The following is a description of a gene set: Human Gene Set: GSE9988_LPS_VS_CTRL_TREATED_MONOCYTE_DN studied in species Homo sapiens Genes down-regulated in comparison of monocytes treated with 5000 ng/ml LPS (TLR4 agonist) versus monocytes treated with control IgG. from publication Dower K, Ellis DK, Saraf K, Jelinsky SA, Lin LL (PMID 18292579) TREM-1 is an orphan immunoreceptor expressed on monocytes, macrophages, and neutrophils. TREM-1 associates with and signals via the adapter protein DAP12/TYROBP, which contains an immunoreceptor tyrosine-based activation motif (ITAM). TREM-1 activation by receptor cross-linking is pro-inflammatory, and can amplify cellular responses to Toll-like receptor (TLR) ligands such as bacterial lipopolysaccharide (LPS). To investigate the cellular consequences of TREM-1 activation, we have characterized global gene expression changes in human monocytes in response to TREM-1 cross-linking in comparison to and combined with LPS. Both TREM-1 activation and LPS up-regulate chemokines, cytokines, matrix metalloproteases, and PTGS/COX2, consistent with a core inflammatory response. However, other immunomodulatory factors are selectively induced, including SPP1 and CSF1 (i.e., M-CSF) by TREM-1 activation and IL-23 and CSF3 (i.e., G-CSF) by LPS. Additionally, cross-talk between TREM-1 activation and LPS occurs on multiple levels. While synergy in GM-CSF protein production is reflected in commensurate mRNA abundance, comparable synergy in IL-1b protein production is not. TREM-1 activation also attenuates the induction of some LPS target genes, including those that encode IL-12 cytokine family subunits. Whereas positive TREM-1 outputs are abolished by the PI3K inhibitor wortmannin, this attenuation is largely PI3K-independent. These experiments provide a detailed analysis of the cellular consequences of TREM-1 activation, and highlight some of the complexity in signal integration between ITAM- and TLR-mediated signaling., and this is the list of marker genes: APOBR, BRD1, KIAA2013, ORAI2, DAGLB (diacylglycerol lipase beta, NCBI Gene Id 221955), THEMIS2, BMF, APMAP, GLE1, ASB7, CALHM2, TRAPPC12, DUSP10, TGFBR2, PRPF6, GDE1, TNFAIP8L2, FBXO7, KANSL1, RAP2B, MARF1, SNRK (NCBI Gene Id 87229), ZNF432, USP22, PTP4A2, RIC8A, NELFB, POLDIP3, PRELID1, FRAT2, CHAMP1, G3BP2, MNT, CHCHD4 (coiled-coil-helix-coiled-coil-helix domain containing 4), NUP62, SF3B2, MBD2, MLXIP, PLEKHO2, FRAT1, PLXNB2, PCBP1, MSRB1, FAM89B, ENC1, SASH3, NLRC4, ATXN7L3, RGS19, SLC31A2, ORAI3, SNAPIN, PHF23, CASP8, TLR1, RNF7, DDX23, ZNF226, STX6, EVI2B, FOXK1, ARHGAP30, KDM3B, CSF1R, ZNF282, ELOVL1, LRRC25, GTF3A, MEAF6, GABARAP, TMEM121B, WIPI2, SDHAP1, DCAF12, CTCF, KLHDC3, SNX17, PHC2 (NCBI Gene Id 1912), SMG8, IFFO1, FBXO21, RETREG3, SLBP, MAP3K14, BAG4, MAST3, CHD8, PGP, VRK3, CXCR4, ISCA2, CCR2, SNX20, PDLIM2, ZBTB44, ZNF398, ARL6IP5, TPRG1L (tumor protein p63 regulated 1 like), DOK2, CXCL16, VPS35, NUP50, TRIM38, UBALD2, TNFAIP8L1, YY1, RSC1A1, CBL, CSK, FYTTD1, GIT2, NAGA, MKRN1, DCAF5, TAF5, FHOD1, ADSL, SLC9A6, TOR1A, RUNDC1, FADD, RAB8A, PLEKHO1, GLTP, MLX, BAP1, RALA, OSBPL11, CNBP (NCBI Gene Id 7555), SYNRG, DEDD2, LMO2, GLUD2, SETD1B, CMTM3, ARAP1, FRMD8, ZNF740, TFEB, ZDHHC7, HINFP, PPP1CA, TCF20, WBP1L, PAGR1, CNOT8, EVI2A (NCBI Gene Id 2123), NELFA, HHEX, NAP1L4, PHAF1, RETREG2, ARRB2, KLHDC10, ARHGAP1, LASP1, ARPC1B, CRTC3, DPP8, WASF2, RPS19BP1, NRBP1, SRSF9, MAPK14, PSMG2, ANKRD13A, ZNF615, DNAJC13, MAP7D1, PPP1R8, CMTM7, PLIN3, BRPF1, BRD8 (bromodomain containing 8), PAFAH1B2 (platelet activating factor acetylhydrolase 1b catalytic subunit 2), CTDSP1, NCOA6, HECA, IFT20, ACBD5, KLF13, ARRDC2, EIF4EBP2, TSC22D3, USP3, DNAJC5, PIP5K1C, RNF38, PRR13 (proline rich 13), CLIC1, ZNF689, NUP214, CCDC69, RALB, SMARCAL1, MYO1F, CTDSP2, DUSP7, UBAC1, GRN